The following is a description of a gene set: species: Homo sapiens Human Gene Set: chr8p22, and this is the list of marker genes: MTMR7, MTUS1-DT, PDGFRL, C8orf48, DLC1, MTUS1, CCT3P1, ENSG00000304219, RPL35P6, RNA5SP255, TRMT9B, PSD3, ABRAXAS1P2, ASAH1, SGCZ, ENSG00000286798, SNORA62, RN7SL474P, MTND4LP26 (NCBI Gene Id 107075104), RNU6-842P, FGF20, EIF4EP5, ZDHHC2, NAT1, MICU3, CNOT7, MIR383, TUSC3, ADAM24P, MIR548V, PCM1, VPS37A, RNU6-397P, NAT2, SLC7A2, NATP, RPL32P19, LINC03019, PPM1AP1, ASAH1-AS1, MRPL49P2, MSR1, MTND4P7, ENSG00000254242, FGL1, RNA5SP256, RNU7-153P